The following is a description of a gene set: Human Gene Set: REACTOME_HIGHLY_SODIUM_PERMEABLE_POSTSYNAPTIC_ACETYLCHOLINE_NICOTINIC_RECEPTORS studied in species Homo sapiens Highly sodium permeable postsynaptic acetylcholine nicotinic receptors, and this is the list of marker genes: CHRNB2, CHRNB4, CHRNA3, CHRNG, CHRNA4, CHRNE, CHRND